Given this list of marker genes SPI1, CD79A, IGLL1, FNIP1, BTK, TNFRSF9, SLC39A7, here is a description of the gene set: Human Gene Set: HP_ABSENT_CIRCULATING_B_CELLS Absence of detectable circulating B cells, commonly characterized as CD19+ or CD20+ lymphocytes, in the blood. Usually, less than 20 cells per microlitre is considered to be an absence. Absent circulating B cells species: Homo sapiens